The following is a description of a gene set: The chemical reactions and pathways resulting in the breakdown of retinoic acid, one of the three components that makes up vitamin A. Mouse Gene Set: GOBP_RETINOIC_ACID_CATABOLIC_PROCESS studied in species Mus musculus, and this is the list of marker genes: Cyp26a1, Cyp2w1, Klf9, Cyp26c1, Cyp26b1, Strap, Sp1